The following is a description of a gene set: Mouse Gene Set: GOBP_CHOLESTEROL_EFFLUX The directed movement of cholesterol, cholest-5-en-3-beta-ol, out of a cell or organelle. species: Mus musculus, and this is the list of marker genes: Ces1h, Lipa, Naxe, Ces1e (carboxylesterase 1E), Abcg8, Cav1, Soat2, Srebf2, Comt, Ces1g, Irak1, Ttc39b, Trem2, Apoe, Apoc3, Ces1d, Apoc1, Nfkbia, Adipoq, Zdhhc8, Ces1b, Abcg4, Abca3, Pparg, Nfkb1, Gps2, Abcg5, Abca2, Apof, Lamtor1, Ces1f, Tsku, Eepd1, Ces1a, Spg11, Nr1h3, Abca8a, Apoa5, Egf, Apob, Ttc39d, Abca7, Abca12, Pltp, Scarb1, Soat1, Pon1, Abcg1, Sirt1, Pla2g10, Abca5 (NCBI Gene Id 217265), Mexis, Npc2, Lrp1, Apoa2, Stx12, Ces1c, Shh, Abca8b, Ptch1, Apoc2, Apom, Npc1, Apoa4, Abca1, Apoa1, Nr1h2, Apoc2l, Yjefn3